Given this list of marker genes SERPINB2, ALOX5AP, CDKN3, DYNLL1, GMFB, RFC3, PPP1R11, HSPB2, ARF5, MGST2, PPP2CB, SCG5, ZEB2, PPP4C, DUSP5, DUSP6, CXCL1, PPP2CA, PPP1CC, ARF4, PPM1D, UBA2, DUSP14, ARL1, PRPSAP1, TRIM23, PPP6C, here is a description of the gene set: species: Homo sapiens Genes in the cancer module 226. Human Gene Set: MODULE_226